The following is a description of a gene set: Any process in which the microtubule organizing center is transported to, and/or maintained in, a specific location within the cell. Human Gene Set: GOBP_MICROTUBULE_ORGANIZING_CENTER_LOCALIZATION species: Homo sapiens, and this is the list of marker genes: TBCCD1, SUN2, ASPM (assembly factor for spindle microtubules), IFT20, MISP, MAD2L1 (NCBI Gene Id 4085), GPSM2, NDEL1, PLXNA2, SPOUT1, NDE1, CEP83, CCDC141, SUN1, TMEM201, SYNE2, BICD2 (NCBI Gene Id 23299), RANBP2, PKHD1, KIF5B, PARD3, AURKA, FHOD1, INTS13, PAFAH1B1, DLGAP5, DLG1, EZR (ezrin), NUBP1 (NCBI Gene Id 4682), AKAP9, NIN, PARD3B, DYNC1LI2